Given this list of marker genes CES1, CACNA2D3, C1orf54, ENSG00000274253, APOC2, CD70, TGM5, NXT2, TRPM4, UVRAG, XAGE1B, CEP15, MSLN, ACSL4, TKTL1, RET, LAMP5, HIF1A, PENK, CADM1, P2RY2, ITGA7, DACH1, here is a description of the gene set: BACKGROUND: In patients with acute myeloid leukemia (AML) a combination of methods must be used to classify the disease, make therapeutic decisions, and determine the prognosis. However, this combined approach provides correct therapeutic and prognostic information in only 50 percent of cases. METHODS: We determined the gene-expression profiles in samples of peripheral blood or bone marrow from 285 patients with AML using Affymetrix U133A GeneChips containing approximately 13,000 unique genes or expression-signature tags. Data analyses were carried out with Omniviz, significance analysis of microarrays, and prediction analysis of microarrays software. Statistical analyses were performed to determine the prognostic significance of cases of AML with specific molecular signatures. RESULTS: Unsupervised cluster analyses identified 16 groups of patients with AML on the basis of molecular signatures. We identified the genes that defined these clusters and determined the minimal numbers of genes needed to identify prognostically important clusters with a high degree of accuracy. The clustering was driven by the presence of chromosomal lesions (e.g., t(8;21), t(15;17), and inv(16)), particular genetic mutations (CEBPA), and abnormal oncogene expression (EVI1). We identified several novel clusters, some consisting of specimens with normal karyotypes. A unique cluster with a distinctive gene-expression signature included cases of AML with a poor treatment outcome. CONCLUSIONS: Gene-expression profiling allows a comprehensive classification of AML that includes previously identified genetically defined subgroups and a novel cluster with an adverse prognosis. Genes that best predicted acute myeloid leukemia (AML) with the 11q23 rearrangements. from publication Valk PJ, Verhaak RG, Beijen MA, Erpelinck CA, Barjesteh van Waalwijk van Doorn-Khosrovani S, Boer JM, Beverloo HB, Moorhouse MJ, van der Spek PJ, Löwenberg B, Delwel R (PMID 15084694) Human Gene Set: VALK_AML_WITH_11Q23_REARRANGED studied in species Homo sapiens